Given this list of marker genes CIP2A, GABRG2, ATP2B4, RNF44, CPNE5 (copine 5), ZRANB1, TMEM117, PBDC1, CAP1, UBLCP1, U2SURP, EYS, CDC27, SLC2A3, ARPC2, CSTF1, PPP1R26, YWHAE, PCDHB13, THAP10, SERINC4, SLC22A15, CHORDC1, BRWD3, RTKN2, AKAP9, HMCES, HNRNPA2B1, BTBD10, CAPS2, POU4F2 (POU class 4 homeobox 2), LAGE3, PFKFB2, NAP1L1, NPAS3, UBE2N, DIP2C, EXO5, ARL13A, BECN1, ZNF570, ZDHHC17, SLC39A10, FBXO30, DOCK1, CSTF3, SLC16A4, ADAM10, ATXN1, MTA2, PIK3C2B, CCDC169-SOHLH2, NEDD9, PTGS1, CELA1, ZNF225, ZDHHC21 (zinc finger DHHC-type palmitoyltransferase 21), SUN2, FAT3, KMT5B, MAP4, SAMD4B, WNK3, SF3B2, TAF4, MAP3K8, SNX9, MAPK1 (NCBI Gene Id 5594), GEMIN5, LIAS, CACUL1, HMBOX1, PHF21A, TMLHE, TANC1, MATR3, BRINP2, ZNF426, VXN, NAMPT, TRIM39, ROBO1, GLUL, OR2H1, DLEU7, NAA20, ATP5MK, NBEA, PDXK, SQSTM1, CPEB2, MAP3K2 (NCBI Gene Id 51777), MORF4L2, JTB, SOCS6, EPS8, NCKAP1, NUFIP2, AARD, DCAF10, TUT4, CADPS2, CACHD1, EPN2, here is a description of the gene set: Human Gene Set: MIR548B_3P Genes predicted to be targets of miRBase v22 microRNA hsa-miR-548b-3p in miRDB v6.0 with MirTarget v4 prediction scores > 80 (high confidence targets). from publication Chen Y, Wang X (PMID 31504780) species: Homo sapiens